The following is a description of a gene set: species: Homo sapiens Genes having at least one occurrence of the motif NNNTNAAGGTCANN in the regions spanning 4 kb centered on their transcription starting sites. This matches the ESRRA transcription factor binding site V$ERR1_Q2 (v7.4 TRANSFAC). Human Gene Set: ERR1_Q2, and this is the list of marker genes: CHD2, USP8, TEF, MSI2, OBSCN, DLG2, CSNK2A1, SSR4, AOC2, ZMAT4, MYL3, LDB3, ARF6, SHB (NCBI Gene Id 6461), SNTG1, TTLL7, MRPL48, YTHDF2, TIMM8B, SMPD1, GRIK3, SORCS1, MTSS2, DEPDC7, ACO2, MEF2C, WDFY3, DIRAS1, JADE2, KCNH2, MAP1B, SNX18, PSIP1, TIMM9, PRKG2 (NCBI Gene Id 5593), C6orf47, SUCLA2, ATP5MC1, ADCY1, KIRREL3, MAP4K2, CDHR1, TNRC6A, ELAVL3, NOG, STAC2, LCA5, CLUH, STRN, ACTR1A, RXFP4, BPNT2, RAB35, UCHL1, PCBP4, NAV1, ATP6AP2, HDAC11, MGST3, GOT1, ANKRD28, CTDSPL2, ATP5MF, PRR7, RBM39, PPP4R3A, KDM5A, RNF128 (NCBI Gene Id 79589), ENO3, PANK1, RGS4, CLPTM1, RNF19B, THRA, TMTC1, SOCS4, RPH3A, MNT, HSPD1, ZRANB1, PPP2R5D, ITGA3, HCN4, ESRRA, SEMA7A, PHB1, RAB3A, JMJD1C, RNF2, LIMK1, SATB1, LRFN4, FBXL17, PCDH7, TCF7, KIRREL3-AS3, VSNL1, HOXA3, VDAC2 (NCBI Gene Id 7417), MB, HECTD2, HTATSF1, LHX2, STARD13, BUB1B, NDRG2, HCRTR1, RS1, KIF3B, SLC25A5, VCL, SPMIP6, SRPK2, PHF6, RNF44, CNTF, UQCRC2, VASP, GPBP1L1, GEMIN7, UQCRC1, BEND6, FBXL19, WWC1, RAB11FIP5, PGAP2, RNF139, ATP6V1A, SLC31A2 (NCBI Gene Id 1318), ANGPT1, SDHD, CDH16, RIMS4, PRRC2C, BCKDHB, ISCU, PIM1, ZNF664, APP, FGF9, HSPE1, FZD9, SCN5A, WDFY3-AS2, ABCC5, TAOK2, ZNF296, GDPD1, NAA25, CNTN2, MBOAT2, ASCC1, SARNP, HOXA5, KCNK1, RHCG, RASGRP2, SLC37A2, AIFM1, XYLT2, SAG, VAMP1, ABAT, CCDC9B, GAPDH, KAT6A, FBXW4, XYLT1, KIF5A, LMO3, DIAPH1 (diaphanous related formin 1), CKMT1B, COX7B, FGL1, ID3, PPM1E, TMEM35A, KCNG4, SIRPA, SPATS1, SPAG9, HHATL, WBP1L, AFP, FBRS, TAB3, TBC1D15, CYTH2, PLPPR2, SLC38A3, TGM6, CX3CL1, NTF3, BZW2 (NCBI Gene Id 28969), SMARCC2, BRME1, RREB1, ARHGEF38, RUNX1T1, GK, CACNB2, TM2D2, PLCB3, FBXL22 (NCBI Gene Id 400380), IDH3G, RFX5, UHRF2, KIAA0586, SRXN1, NR4A1, RELT, RAP2C, EIF4H, PABIR3, VAMP2, RASAL1, KCNN1, MFSD8, EPN3, CXXC5, SDHB, MPRIP, AFG3L2, TFEB, MMP24, MPC2, DLC1, ANKRD13A, NALF2, SCNN1A, RIPOR1, SLC30A3, HS6ST2, IQSEC1, KLK15, WDR72, MAP1A, ZDHHC21, GJB2, ATP5F1A, ATXN7L2, SEC61A1, TMCC1, SCNN1G, NR2C2, CNTLN, VDAC1, SRCIN1, PVALB, RYR3, ADAM9, RAPGEF5, H4C3, PHF5A, URGCP, UNC5B, PPTC7, SLC22A11, HNF1B, VSTM2L, NXPH4, KDM5C, NEFM, NAA50, HSPA9, SOD3, SART3